The following is a description of a gene set: p53 and p63 belong to a family of sequence-specific transcription factors regulating key cellular processes. Differential composition of the p53 and p63 DNA-binding sites may contribute to distinct functions of these protein homologues. We used SELEX (systematic evolution of ligands by exponential enrichment) methodology to identify nucleic acid ligands for p63. We found that p63 bound preferentially to DNA fragments conforming to the 20 bp sequence 5'-RRRC(A/G)(A/T)GYYYRRRC(A/T)(C/T)GYYY-3'. Relative to the p53 consensus, the p63 consensus DNA-binding site (DBS) was more degenerate, particularly at positions 10 and 11, and was enriched for A/G at position 5 and C/T at position 16 of the consensus. The differences in DNA-binding site preferences between p63 and p53 influenced their ability to activate transcription from select response elements (REs) in cells. A computer algorithm, p63MH, was developed to find candidate p63-binding motifs on input sequences. We identified genes responsive to p63 regulation that contain functional p63 REs. Our results suggest that the sequence composition of REs could be one contributing factor to target gene discrimination between p63 and p53. studied in species Homo sapiens Genes up-regulated in HMEC cells (primary mammary epithelium) upon expression of both of TP53 and the transcriptionally active isoform of TP63 off adenoviral vectors. Human Gene Set: PEREZ_TP53_AND_TP63_TARGETS from publication Perez CA, Ott J, Mays DJ, Pietenpol JA (PMID 17563751), and this is the list of marker genes: PLCXD2, SLC9A3, PGAP1, OGA, AUTS2, OTULINL, SHC4, MAFB, CNKSR3, EVPL, EDDM13, ITSN2, CHST2, KCNK3, DPYSL4, ADAP2, ZIC2, PTX3, ARHGEF6, AQP3, PPP1R13B, STOX2, TM7SF2, NPIPA1, FOXF1, STAR, ZNF385A, PLPP3, TNFRSF10D, LY6D, RASSF5, EPHB3, SLIT2, DHRS3, TENT5C, ST8SIA2, MYLIP, SEMA4D, NLRP1, SLC35E4, CDKN1C, GRHL3 (grainyhead like transcription factor 3), MOXD1, TSC22D3, PLCD1, NPIPB3, PPP1R16B, WNT7B, CELF2 (NCBI Gene Id 10659), RAB11FIP1, MEGF6, SMAD7, CGNL1, PLIN4, CRISPLD2, EPB41L3, RAB11FIP4, CABP7, CX3CL1, LINC01666, BLMH, BMP2, NTN1, ABHD6, SUSD2, KISS1R, TRIM8, HSD11B2, ID4, MAF, KCNJ12, FAM43A, RORA, HS6ST1, EPB41L4B, PALMD, IGFBP3, RBP7, PPP2R2C, BIK, MXRA5, GPT2, CNNM4, SIPA1L2 (NCBI Gene Id 57568), LBH, GNA11, ARX, COL9A3, REEP1, NOTCH3, NEFL, ZNF750, CAPN3, COL18A1, GABRE, GPR37, TAF5, ARRB1, ERFE, ZNF436, SPATA13, LRRC37A4P, NGFR, RASGRP1, NPTX1, GPATCH2L, HUNK, RBM38, RET, VASN, ARID1B, EPB41, CASZ1, NPPC, COL27A1, METRNL, CRAMP1, RAB11FIP3, FZD1, SMAD9, ZNF600, SLC16A14, C7orf57, ARHGEF17, FGF13, ARG2, UBE2Q2P1, IGF2, INSR, BCOR, CXCL14, TACC1, GLIS2, EGR1, GALR2, MARCHF3, SASH1, ZCCHC24 (NCBI Gene Id 219654), IGF1R, NRARP, GRTP1, ELMOD1, SERINC5, ENSG00000255367, TAF3, SLC4A11, MICALL2, SELENOP, RHOB, LONRF3, ZSWIM6, KLHL21, FGF18, KSR1, PGF, DEDD2, EPPK1, PCSK5, SMAD6, GMCL1, MAN1C1, ID2, TUFT1, ANKRD20A11P, VDR, APC2, ULBP2, IRX5, CRYAB, DOC2B, RGCC, WFDC5, PTPRJ, CGAS, DOK4, SHANK3, FOXF2, NUAK1, TOX, BCL2L11, BAMBI, FOXP4, HIC2, VSIR, TNRC6C, FRY, THEMIS2, PAK6, RASEF, RTN4R, CKB, MAP7, ARIH1, ABTB3, CITED1, ULK1, ADCY1, IHH, ZFYVE1, HR, APAF1, UNC5B, GRK5, SOX8, UBE2QL1, SHISAL1, MX1, WHRN